The following is a description of a gene set: studied in species Homo sapiens Protrusion of the contents of the abdominal cavity through the inguinal canal. Inguinal hernia Human Gene Set: HP_INGUINAL_HERNIA, and this is the list of marker genes: ERI1, COL1A1, CTNND2, CTCF, PLAG1, DGCR6, KDM3B, NFIA, DNAJC30 (DnaJ heat shock protein family (Hsp40) member C30), TBX3, CHST3, NOTCH2, NPHP3, PYCR1, EFEMP2, DLX4, KDM5B, CWC27, AMHR2, LDHD, UBA1, ZFX, DVL1, GNE, SKIC2, WASHC5, TGDS, GDF11 (NCBI Gene Id 10546), TRPV6, TRAF7, SEC31A, OFD1, TMCO1, ZEB1, DICER1, CHD3, ALDH18A1, WDR35, C1S, ACTA2, DVL3, GTF2IRD1, APC2, GPC3, HSPG2, B3GLCT, KDM6A, TGFB3, FAT4, SERPINH1, KMT2C, NCF1, TGFBR2, FBLN5, ARID1B, FLNB, RAB3GAP2, ADAMTSL2, ATP7A, RREB1 (ras responsive element binding protein 1), POGZ, CREBBP, GP1BB, MED12, ARPC4, GUSB, THSD4, ATP6V1E1, PLOD1, AGA, PIK3R1, GATA4, SEMA5A, CSNK2A1, CDC42, BUD23, COL1A2, TBL2, SET, GTF2I, FARSB, MAT2A, PACS1, GTF2IRD2, FKBP14, RIC1, GLRA1, AUTS2, CLCN4, PIGQ, YWHAE, BCR, MEG3, TUBB, FLNA, CCDC22, MYH11, SLC10A7, GALNS, EIF4H, MTFMT, ATP6V1A, ARID1A, COMT, SMAD4, H19, METTL27, DLK1, DSE, GNPTAB, FBN1 (NCBI Gene Id 7470), FLI1, ARSB, BRF1, NXN, DNAJB4, MED25, TMEM107, TBX1, MYH3, HES7, SATB2, DGCR2, NDUFA8, SLC2A10, NSD1, SMAD3, SMCHD1, KIF7, VPS37D, BRAT1, MEIS2, TP63, MAF, DPYSL5, PORCN, ELN, CDKN1C, GDF1, BRD4, PRDM5, FANCB, PRKG1 (NCBI Gene Id 5592), TGFBR1, RIPPLY2, RIPK4, LOX, BUB1, NEU1, SHOC2 (NCBI Gene Id 8036), CC2D2A, TAF4, NAA10, SETBP1, MFAP5, TMEM270, CRELD1, DEPDC5, FBXW11, NALCN, ADAMTS15, GNPAT, G6PC3, SH3PXD2B, SEC24C, BAZ1B, RNU4-2, IDUA, SKIC3, SUZ12, KMT2D, B3GAT3, EFEMP1, FGD1, RFC2, ESS2 (ess-2 splicing factor homolog), GNS, PPP2R1A, STX1A, UFD1, FZD2, TOR1A, CBS, RNF13, GLB1, MYLK, PTDSS1, IRX5, TASP1 (taspase 1), LRPPRC, PLOD2, CHST14, LIMK1, CLDN19, IFT56, DYRK1A, SMAD2, NIPBL, SMARCB1, GNB2, PIGY, GRIN2B, LTBP1 (latent transforming growth factor beta binding protein 1), MBTPS1, SLC26A2, EHMT1, GLI3, HIRA, NOTCH1, NAT8L, DLL3, FGFR1, AP1S2, DPH2, TNRC6B, MESP2, IFT122, SLC37A4, POLR2A, IPO8, RPL10, COL5A2, HOXC13, ADAMTS2, RAP1B, ATP1A2, AHDC1, AEBP1, COL2A1, SHPK, TMEM67, DPH1, ODC1, PIGS, IDS, NOTCH3, SMARCA2, DDX6, GATA6, COL5A1, SGSH, PIGW, MAPRE2, ABCD4, ATP6V0A2, MID1, COX11, SRCAP, AR (androgen receptor), VPS35L, FOCAD, C1R, KCNQ1OT1, COL3A1, MAN2B1, SMARCC2, AMH, TXNL4A, CRKL, P3H1, TGFB2, ISL1, FBXL4, DPP9, WDR19, RPGRIP1L, STRA6, PUF60, JMJD1C, MLXIPL, PHGDH, HEY2, GPHN, ROR2, CHRNG, INPP5E, SIN3A, FIBP, TRRAP, CUL4B, PIGL, BMPER (NCBI Gene Id 168667), ADNP, PIEZO2, IGF2, GZF1, GPC4, WNK3, OCRL (NCBI Gene Id 4952), ARX, CLIP2, FOXE3, ATAD1, WNT5A, DGCR8, MBTPS2, MAPK1, FKBP6, RTL1, LTBP4, RPS6KA3, LFNG (LFNG O-fucosylpeptide 3-beta-N-acetylglucosaminyltransferase), ARVCF, TMEM70, POLR1A, HMGA2, SKI, MDFIC, PLD1, PAFAH1B1, DIS3L2 (NCBI Gene Id 282696), XRCC4, PPP2CA, EZH2, SLC5A6, ELOVL4